Given this list of marker genes RNF168, BTNL2, NRAS, CD40LG, TLR4, POMP, STXBP2, RBCK1, PRKAR1A, ZBTB16, CD70, STING1, H19, TRIP13, LYST, MIF, RAC2 (Rac family small GTPase 2), FASLG, ITGAM, IL6, PALB2, TERT, TRIM28, STX11, IL12A, GINS1, CTLA4 (cytotoxic T-lymphocyte associated protein 4), PML, P4HA2 (NCBI Gene Id 8974), MCTS1, PRKCD, TGFBR2 (NCBI Gene Id 7048), BCOR, ZAP70, CD27, NABP1, SMPD1, CYBC1, CR2, CXCR4, TSC2, AICDA, ATRX, STAT2, SNX10, BRCA1, MVK, IL12RB1, EWSR1, NFKBIA, IRF4, STAT4, BTK, PSMB8, RNU4ATAC, HLA-DPB1, AGR2, RASGRP1, TP53, BCL2, ADA, TSC1, TLR7, BRCA2, NLRP3, IRAK1, MALT1, NFATC2, TRAC, PHOX2B, LCAT, NFKB1, TNFSF12, MEFV, EPHB4, ZNFX1, YARS1, ANKRD55, SMAD4, BIRC3, OTULIN, EIF2AK4, IRF2BP2, NFKB2, TREX1, CASP10, SRSF2, CCR1, PALLD, XIAP, LIG4, ADA2, CHD7, CBL, ARPC1B, RFX5, PIK3R1, SH3BP2, CASP8, NCF1, IFNGR1, ETS1, IRF8, IL7R, PXK, ALK, TNFSF4, IL23R, TET2, ISG15, DNASE1, KIAA0319L, DLEC1, CD247, TNFRSF13B, C4B, PSMB10, TNFRSF1A, FOXP1, PTPN22, ERAP1, ITK, NCKAP1L, CLCN7, RAG2, HMOX1, PDGFB, ABCA1, BCL6, PRF1, PTPN2, ATM, IRF1, PNP, UBAC2, IL2RB, JAK3, APOE, RAG1, TBL1XR1, TNFRSF9, FIP1L1, LAT, SPP1, FOXE1, MS4A1, CD28, CARD9, TPP2, CDKN2A, PIK3CG, RIPK1, CALR, IL6ST, HLA-DRB1, STAT3, DCLRE1C, UBE2L3, LACC1, SH2D1A, MINPP1, UNG, KLRC4, SAT1, RUNX1, XRCC4, BRAF (B-Raf proto-oncogene, serine/threonine kinase), STAT5B, SOCS1, HABP2, PLCG1, RAB27A, CD81, FERMT3, IKBKG, SLC29A3, C4A, BCL10, WWOX, MYD88, BANK1, IL10, NUMA1, ASXL1, MPL, RNF6, UNC13D, CD40, COL1A1, CCBE1, HLA-B, IL2RA, PSMG2 (proteasome assembly chaperone 2), HACE1, WT1, TNFRSF13C, FCGR2B, MCM4, CYBA, RMRP, KIT (KIT proto-oncogene, receptor tyrosine kinase), MECP2, ADAMTS3, STIM1, IFIH1, TNFSF11, DIS3L2, FAT4, ACP5, NOD2, SHARPIN, GATA2, POU6F2, DNASE1L3, SP110, STAT1, PIK3CD, CTNNBL1, IL12A-AS1 (IL12A antisense RNA 1), KRAS, DEF6, RARA, PTEN, NLRP12, SDHD, PSTPIP1, FAS, IGHG1, TNFRSF1B, IL2RG, CCND1, LIN28B, BLK, PTPRC, SYK, PDCD1, FOXN1, TNIP1, LMO1, LRBA, POLD3, RABL3, GPC3, MYCN (MYCN proto-oncogene, bHLH transcription factor), NPM1, FCHO1, BAP1, ASAH1, JAZF1, ELANE, TNFAIP3, TLR8, NCF2, FCGR3B, PSMB4, MYC, TBK1, ICOS, NCF4, TCIRG1, REST, WDR1 (WD repeat domain 1), MAP2K1, MAGT1, IRF5, JAK2, CYBB, CD19, FOXP3, here is a description of the gene set: species: Homo sapiens Human Gene Set: HP_ABNORMAL_LYMPH_NODE_MORPHOLOGY A structural lymph node abnormality. Abnormal lymph node morphology